The following is a description of a gene set: Mouse Gene Set: GOBP_NEGATIVE_REGULATION_OF_INTERFERON_ALPHA_PRODUCTION Any process that stops, prevents, or reduces the frequency, rate, or extent of interferon-alpha production. species: Mus musculus, and this is the list of marker genes: Ptprs, Havcr2, Nlrc3, Nmi (NCBI Gene Id 64685), Gbp4